Given this list of marker genes H3-3A, H3C1, H4C8, RPS6KA2, H3C7, FZR1 (fizzy and cell division cycle 20 related 1), H4C12, H3C11, UBE2E1, H2BC7, H2BC5, ANAPC16 (NCBI Gene Id 119504), H3C8, CXCL8, JUN, H2BC12L, H2BC10, ANAPC4, H2BC14, H2BC1, H4C5, CDC26, UBC, H2AZ2, CDKN1A, H2BC9, H2AC14, H2AB1, IGFBP7, RELA, MAPK7, H2BC21, H2AC7, MAPK3, CDKN1B, H2BC26, H2AC8, H3C2, IL1A, VENTX, CDC27, CDK4, CEBPB, H4C1, H2AC18, H3C13, H2BC13, RPS6KA1, CCNA2, EHMT2, H3C10, UBA52, H2AC20, ANAPC7, H4C11 (H4 clustered histone 11), H2BC15, H2AC6, H4C14, H2AC19, RPS27A, MAPK1, H2BC8, ANAPC15, H3C14, CDK2, UBB, ANAPC11 (anaphase promoting complex subunit 11), H3C12, H2AX, H4C2, H2AZ1, RPS6KA3, H2BC11, ANAPC1 (anaphase promoting complex subunit 1), H2BC12, H4C13, ANAPC5, H4C16, UBE2D1, H4C15, H2BC3, IL6, H3-3B, H3C15, ANAPC2, H2BC4, NFKB1, CDC16, EHMT1, H2BC6, H2AJ, H3C6, H3C3, CDC23, ANAPC10, CDKN2D, CDK6, H3C4, CDKN2A, CDKN2C, CDKN2B, H4C4, FOS, STAT3, H2BC17, H4C6, CCNA1, H2AC4, H4C3, UBE2S, UBE2C, H4C9, here is a description of the gene set: species: Homo sapiens Human Gene Set: WP_SENESCENCEASSOCIATED_SECRETORY_PHENOTYPE_SASP Senescence-associated secretory phenotype (SASP)